The following is a description of a gene set: studied in species Mus musculus The uptake of catecholamine neurotransmitters by neurons or glial cells. This process leads to inactivation and recycling of neurotransmitters. Mouse Gene Set: GOBP_CATECHOLAMINE_UPTAKE_INVOLVED_IN_SYNAPTIC_TRANSMISSION, and this is the list of marker genes: Rab3b (NCBI Gene Id 69908), Drd2, Tor1a, Gdnf, Slc6a2, Prkn, Nat8l, Snca, Park7